Given this list of marker genes Trmt10b, Maip1, Mtch1, Hspa4 (heat shock protein 4), Tmem126a, Hsp90aa1, Pdcd5-ps, Tomm40, Pdcd5, Ndufa13, Tomm22 (translocase of outer mitochondrial membrane 22), Timm9, Mtch2, Timm10, Moap1, Bcs1l, Timm29, Samm50, Agk, Tomm70a, Timm13, Romo1, Oxa1l, Bax, Cox18, Ap3b1, Timm22, here is a description of the gene set: Mouse Gene Set: GOBP_ESTABLISHMENT_OF_PROTEIN_LOCALIZATION_TO_MITOCHONDRIAL_MEMBRANE studied in species Mus musculus The directed movement of a protein to a specific location in the mitochondrial membrane.